The following is a description of a gene set: Mouse Gene Set: GOBP_POSITIVE_REGULATION_OF_HEMOPOIESIS Any process that activates or increases the frequency, rate or extent of hemopoiesis. studied in species Mus musculus, and this is the list of marker genes: Foxp3, Tmem64, Lif, Il4, Ripk2, Kat5, Irf1, Flt3l, Trem2, Ap3d1, Hmgb1, Pou4f1, Tescl, Pcid2, Ppp2r3c, Ihh (Indian hedgehog), H2-Ea, Vsir, Ccr1, Ccr2, Csf1, Socs1, Ap3b1, Il17a, Arid2, Il4i1, Id2, Xrcc6, Shh, Dlk1 (NCBI Gene Id 13386), Ddrgk1, H2-DMa, Shb, Sox4, Ccl3, Adam8, Actl6b, Ccl9, Carmil2, Stat5a, Nfkbid, Il10, Cd27, Slc9b2, Nlrp3, Smarcd3, Cd74, Eeig1, H2-M3, Bad, Cbfb, Atp11c, Zfp36l1, Socs5, Phf10, Il7, Acin1, Zbtb46, Runx1, Cd83, Il7r, Casp8, Sox13, Cd40lg, Ambra1, Inpp5d, Zbtb7b, Lilrb4a, Nkap, Il2rg, Ccr7, Il12b, Tnfsf4, Rhoh, Creb1, Hsp90aa1, Il20, Pnp, Ror2, Rara, Gpr68, Smarcd2, Il2ra, Prkca, Arid1a, Tox, Fadd, Axl, Pbrm1, Egr3, Tnf (NCBI Gene Id 21926), Rasgrp1, Trib1, Asxl2, Prkdc, Il4ra, Hax1, Sash3, Ptprc, Cd46, Itpkb, Zbtb1 (zinc finger and BTB domain containing 1), Lilrb4b, Zfp609, Ctnnbip1, Gimap5, Ppp3ca, Ccl5, Il6, Malt1, Pck1, Il34, Sox12, Il36b, Prkcz, Gas6, Smarca2, Il15, Zmiz1, Nedd9, Itgb3, Spi1, Lck (NCBI Gene Id 16818), Il2, Il15ra, Ripk1, Pla2g3, Mmp14, Car2, Klhl25, Ikzf1, Cyld, Foxo3, Il1rl2, Actl6a, Tnfsf11, H2-Aa, Smarcc2, Runx3, Rptor, Skint1, Hlx, Ager, Pik3r6, Hcls1, Notch2, Ccl19, Gata3, Xbp1, Il12a, Klf10, Traf6, Tgfbr2, Sart1, Tnfrsf11a, Lef1, Fos, Bcl6, Cd1d1, Opa1, Evi2 (ecotropic viral integration site 2), Lgals9, Rag1, Nfkbiz, Btn2a2, Il18, Syk, Cd101, Tesc, Jun, Mdk, Nckap1l, Zap70, Tespa1, Il23a, Itgam (NCBI Gene Id 16409), Gimap3, Rhoa, Hsf1, Csf1r, Wnt10b, Ocstamp, Tyrobp, Il3, Ninj1, Ada, Mir326, Smarce1, Il21, Rb1, Brd4, Gsk3b, Ifng, Smarcb1, Tnfsf9, Il5, Brd7, Gli3, Fes, Smarcc1, Actb, Kitl, Brd2 (NCBI Gene Id 547337), Smarca4, Gnas, Stat5b, Ppargc1b, Ccr1l1, Smarcd1 (NCBI Gene Id 83797), Mir223, Cd4, Ep300, Dusp10, Anxa1, Evi2b, Tgfb1, Vnn1, Dcstamp, Gfi1b, Pou4f2